Given this list of marker genes Gm15245, Gm15238, Gm25651, Tceanc, Rab9, Piga, Gm15228, Gm15230, Gm15247, Gm6744, Rnf138rt1 (NCBI Gene Id 74264), Prps2, Gm8814, Fancb, Arhgap6, Ofd1, Glra2, Gm15223, Mospd2, Gm15229, Gemin8, Amelx, Tmsb4x, Ace2, Gm15226, Vegfd, Egfl6, Tlr7, Gm15240, Gm8817, Gm15225, Car5b, Gm15246, Ap1s2, Hccs, Gm26368, Siah1b, Asb11, Cltrn, Rpl7a-ps11, Capza1b, Msl3, Gm15216, Frmpd4, Erdr1, Gm1720, Tlr8, G530011O06Rikx, Asb9 (NCBI Gene Id 69299), Trappc2, Zrsr2, Mid1, Gm22023, Gpm6b, Gm15236, Gm15211, Gm15239, Pir, Bmx, Gm8832, Asmt, Gm7209, here is a description of the gene set: Mouse Gene Set: chrXF5 species: Mus musculus